Given this list of marker genes Gas1, Zic3, Hoxa1, Mapk1, Prkra, Tbx1, Fgfr1, Eya1, Mapk3, here is a description of the gene set: The process in which the anatomical structures of the outer ear are generated and organized. The outer ear is the part of the ear external to the tympanum (eardrum). It consists of a tube (the external auditory meatus) that directs sound waves on to the tympanum, and may also include the external pinna, which extends beyond the skull. studied in species Mus musculus Mouse Gene Set: GOBP_OUTER_EAR_MORPHOGENESIS